The following is a description of a gene set: Any process that increases the rate, frequency or extent of cGMP-mediated signaling. Mouse Gene Set: GOBP_POSITIVE_REGULATION_OF_CGMP_MEDIATED_SIGNALING species: Mus musculus, and this is the list of marker genes: Nppc, Rundc3a, Guca1a, Adora2b (NCBI Gene Id 632506), Npr2, Kdr, Nppa, Npr1, Gucy2d, Nppb